Given this list of marker genes PRRX1, TRIB3, NQO1, HLA-B, GAST, EPHX1, NDRG1, CD34, TSPO, GPR137B, PRR13, PTGES, ANXA8L1, ALDH2, ACAA2, GTF3C5, ATF3, CP, TNXB, PTGR1, TWIST2, CDSN, RND2, RBP1, SEC61A1, ITGB7, PTGFR (NCBI Gene Id 5737), CA6, CCK, here is a description of the gene set: from publication Berenjeno IM, Núñez F, Bustelo XR (PMID 17213802) Human Gene Set: BERENJENO_ROCK_SIGNALING_NOT_VIA_RHOA_UP We have used microarray technology to identify the transcriptional targets of Rho subfamily guanosine 5'-triphosphate (GTP)ases in NIH3T3 cells. This analysis indicated that murine fibroblasts transformed by these proteins show similar transcriptomal profiles. Functional annotation of the regulated genes indicate that Rho subfamily GTPases target a wide spectrum of functions, although loci encoding proteins linked to proliferation and DNA synthesis/transcription are upregulated preferentially. Rho proteins promote four main networks of interacting proteins nucleated around E2F, c-Jun, c-Myc and p53. Of those, E2F, c-Jun and c-Myc are essential for the maintenance of cell transformation. Inhibition of Rock, one of the main Rho GTPase targets, leads to small changes in the transcriptome of Rho-transformed cells. Rock inhibition decreases c-myc gene expression without affecting the E2F and c-Jun pathways. Loss-of-function studies demonstrate that c-Myc is important for the blockage of cell-contact inhibition rather than for promoting the proliferation of Rho-transformed cells. However, c-Myc overexpression does not bypass the inhibition of cell transformation induced by Rock blockage, indicating that c-Myc is essential, but not sufficient, for Rock-dependent transformation. These results reveal the complexity of the genetic program orchestrated by the Rho subfamily and pinpoint protein networks that mediate different aspects of the malignant phenotype of Rho-transformed cells. Genes up-regulated in NIH3T3 cells (fibroblasts) after treatment with Y27632, an inhibitor of ROCK proteins; the changes did not depend on expression of constitutively active (Q63L) form of RHOA. studied in species Mus musculus